The following is a description of a gene set: Human Gene Set: GOBP_PROTEIN_OXIDATION studied in species Homo sapiens The modification of a protein amino acid by oxidation., and this is the list of marker genes: APOA2, APOA1, LOXL2, LOX, SUMF1, LOXL3